The following is a description of a gene set: Human Gene Set: GOBP_RECEPTOR_LOCALIZATION_TO_SYNAPSE species: Homo sapiens Any process in which a receptor is transported to, and/or maintained at the synapse, the junction between a nerve fiber of one neuron and another neuron or muscle fiber or glial cell., and this is the list of marker genes: MKLN1, DLG1, GRIP1, CACNG4, CNIH3, VWC2, KIF3B, IQSEC2, CACNA2D2, TMEM108, LHFPL4, CLSTN1, KIFC2, EPB41L3, CACNG7, HRAS, DLG4, TYROBP, ZDHHC2, DAG1, ADAM10, NETO1, TRAF6, GABARAP, KIFAP3, VPS26B, SLC12A5, CEP112, GIT1, CACNG3, NPTX1, GHSR, LRRC7, GPSM2, DLG3, OLFM1, KIF5B (kinesin family member 5B), RAP1A, ZDHHC3, KIF5A, NPTN, SCRIB, ARHGAP44, C1QL3, KIF17, GPHN, OGT, CACNG8, SHISA6, GRIPAP1 (NCBI Gene Id 84538), DLG2, STX3, SACM1L, DBN1, KIF2C (NCBI Gene Id 11004), ERBB2, RELN, VAMP4, CPLX1, RAB4A, ITGB3, GPC4, NLGN1, RAPSN, RAB11A, STX7, C1QL2, MAP2K1, RAB8A, LGI1, GRIP2, KIF5C, VPS35, GPC6, NRXN1, CACNG5, RDX, NETO2, NSG1 (NCBI Gene Id 27065), ERBB4, CACNG2